The following is a description of a gene set: Mouse Gene Set: GOBP_RESPONSE_TO_THYROID_HORMONE A change in state or activity of a cell or an organism (in terms of movement, secretion, enzyme production, gene expression, etc.) as a result of a thyroid hormone stimulus. studied in species Mus musculus, and this is the list of marker genes: Ghsr, Ace, Ppargc1a (peroxisome proliferative activated receptor, gamma, coactivator 1 alpha), F7, Slc26a5, Abcb1a, Crls1, Hes1, Gba1, Tomm70a, Gclm, Gh, Hpn, Ctsb, C2, Thrb, Gclc, Brd8, Inhbb, Rdx, Med1, Stk11, Ctsh, Cab39